Given this list of marker genes Gm30329, Gm9644, Tom1, Otud4, Gm45434, Gm39204, Pou4f2, Gm45446, Gm39288, Ednra, Gm45574, Hmox1, Gm19885, 1700011L22Rik, Slc10a7, Prmt9, Gm47209, Tpd52-ps, Gm22544, Abce1, Rasd2, Anapc10, Lsm6, Gm29895, Gm10649, Gm45407, Mmaa, Isx, Gm2225, Tmem184c, Nr3c2, Gm7901, Gm5909 (NCBI Gene Id 671051), Gm8054, Gm5353, Iqcm, Gm7069 (predicted gene 7069), Gm8077, Smad1, Gm7990, Ttc29, Gm2059, Rbmxl1, Gm24838, Hhip, Gm23260, Mcm5, Gm8079, Gapdhrt2, 0610038B21Rik, 1700093P08Rik, Gm4890, 4933421D24Rik, Gm7984, Gm2253, Umpk-ps, Gm33096, 4933431K23Rik, Gm11033, Hmgxb4, Arhgap10, Gm23981, Zfp827, here is a description of the gene set: studied in species Mus musculus Mouse Gene Set: chr8C1